The following is a description of a gene set: Uterine fibroids are some of the most common tumours of females, but relatively little is known about their molecular basis. Several studies have suggested that deletions on chromosome 7q could have a role in fibroid formation. We analysed 165 sporadic uterine fibroids to define a small 3.2 megabase (Mb) commonly deleted region on 7q22.3-q31.1, flanked by clones AC005070 and AC007567. We also used oligonucleotide microarrays to compare the expression profiles of 10 samples of normal myometrium and 15 fibroids, nine of which displayed 7q-deletions. Activating transcription factor 3, patched homolog (Drosophila), homeo box A5, death-associated protein kinase 1, and retinoic acid receptor responder 3 were downregulated, and excision repair crosscomplementing 3, transcription factor AP-2 gamma and protein kinase C beta 1 were upregulated in fibroids. New pathways were discovered related to fibroid formation. The presence or absence of 7q-deletions did not dramatically affect the global expression pattern of the tumours; changes, however, were observed in genes related to vesicular transport and nucleic acid binding. from publication Vanharanta S, Wortham NC, Laiho P, Sjöberg J, Aittomäki K, Arola J, Tomlinson IP, Karhu A, Arango D, Aaltonen LA (PMID 15940248) Genes up-regulated in uterine fibroids with deletions in the 7q region vs those without the deletion. studied in species Homo sapiens Human Gene Set: VANHARANTA_UTERINE_FIBROID_WITH_7Q_DELETION_UP, and this is the list of marker genes: EMC6, VEZT, ZFP64, PTPN2, HCFC1, PSD3, TIMM9, CNOT2, BCS1L, GOSR2, TSC22D2, RNF138, EMG1, SLC25A38 (solute carrier family 25 member 38), PHGDH, STX18, EIF1AX, ANP32E, YTHDF1, SMARCA4, SLC35A2, CCHCR1, UBR7, IGFBP5, MYDGF, SRSF3, CSE1L, TTC27, FBXO11, NPRL2, RUVBL2, RAD51C, RBBP6, EIF5B, DDX10, NAP1L3, TBPL1, PCMT1, PTP4A1, KERA, MAX, PCF11, TMPO, FBXO21, RBBP7, TCEA1, NXT1, TMEM231, TRAPPC2, ISG20L2, TNFAIP8, RAD23B, VEZF1, NAA16, PAPOLA, ERCC6, TRMT61B, MIA3 (MIA SH3 domain ER export factor 3), EFS, FARP1, HIC2, ZDHHC6, PRUNE2, U2AF1, CARS2, GON4L